Given this list of marker genes ARID5B, XRCC6, MDFIC, DENND2A, PPP3CA, HNRNPA1, RBL1, CREBL2, CYLD, USP3, ADD3, ELK3 (ETS transcription factor ELK3), PEX13, EXOSC1, DCAF17, USP10, TPMT, PLP2, DSTN, PRNP, PRR14L, ANP32E, UPF3A, ICA1, KCNC4, NEFL, AHR, SARDH, CHST7, TSPAN5, RNASET2, RAP1A, FLI1, AKT2, SEPTIN9, SYNE3, TRAPPC3, SLAMF1, SAMSN1, TNKS2, FBXO34, CTNNB1, BAMBI, PIGC, ACAP2, ERH, TAGLN2, HIF1AN, TMX4, ACVR1, TIAM1, ALCAM, CD52, CRIP2, CRIP1, PIM2, CD40LG, NETO2, HECA, EIF4G2, CAPG, IFNAR2, SQOR, FAS, STK24, TMEM123, IL6R, ST8SIA1, GATAD2A, FBXL8, FUT7, MMP15 (matrix metallopeptidase 15), VPS33A, PBXIP1, CRKL, ANKRD55, AP3M2, ZC2HC1A, PGRMC1 (NCBI Gene Id 10857), FAM117A, TNFRSF25, EDEM1, TRIM25, ACAT2, CAPZB, TMBIM6, AQP3, ACP5, CCND2, NFYC, MTM1, TNFSF10, GOLPH3, CBLL1, LDHA, BLVRA, ICOS, CSGALNACT1, TLK1, KIFBP, PPP4R3A, DEK, IL1R1, ITM2B, SUSD6, GLOD4, RAB14, AP2B1, LPAR6, GATA3, ATP8B2, ETS1, TNFRSF4, REEP4, UFM1, LRIG1, CDC5L, AGFG2, TUFT1, NPDC1, BCAP29, CD44, EID1 (NCBI Gene Id 27110), CD4, TRA2A (NCBI Gene Id 29896), MFGE8, HIVEP2, CCDC47, DEGS1, TRAM1, SFMBT1, EVI2B, EPHA4, SNX15, S100A4, CAB39, INPP4B, CD5, APP, RASGRP1, AR, CORO1B, CBR3, BIRC3, PTGER2, MFHAS1, GSR, PHTF2, PDS5A, HNRNPA0, CALM1, TIMP1, RAD23B, SEC31A (SEC31 homolog A, COPII coat complex component), GTPBP3, GOLGA7, TAF15, TECPR2, TMOD3, MAGEH1 (NCBI Gene Id 94692), PACSIN2, PTBP1, TRADD, TRIB2, ASPHD1, EPB41L2, MAP3K1, CCR4, CAST, IL4R, FHL1, CASP2, DSCC1, ELOVL5, ATP1A1, CDKN1B, EIF4EBP2, MINDY1, MUC2, LIMS1, ORC2, DAZAP1, DSTNP2, CHN1, ZFP36L1, ABR, ADGRE1, TBCCD1, AFAP1, CTSB, ATP11A, WDR76, GPR25, CMPK1, CCR10, GPR183, SESN1, LILRB5, CBFB, here is a description of the gene set: Genes down-regulated in comparison of naive CD8 T cells versus naive CD4 CD8 T cells. Human Gene Set: GSE22886_NAIVE_CD8_TCELL_VS_MEMORY_TCELL_DN Immune cell-specific expression is one indication of the importance of a gene's role in the immune response. In order to identify such patterns, we set out to broadly profile gene expression in a variety of immune cells. from publication Abbas AR, Baldwin D, Ma Y, Ouyang W, Gurney A, Martin F, Fong S, van Lookeren Campagne M, Godowski P, Williams PM, Chan AC, Clark HF (PMID 15789058) studied in species Homo sapiens